Given this list of marker genes TMEM183A, PIGC, SMYD3, FBXW2, RCOR3, TMEM106B, TTC13, LPGAT1, YY1AP1, RAP2A, EFNA1, SUN1, WDR26, CHKA, NUAK1, HSPA14, GORASP2, PRCC, MFF, NCK2, SYNJ2, TOR3A, RPS6KC1, SLC29A1, CAMSAP2, AFP, ARF1, MYH4, TMEM260, MKKS, H1-0, RBM34, TUG1, ATRN, CEBPA, CREB3L2, FGFR4, UXS1, SCAMP3, ZNF281, here is a description of the gene set: from publication Boyault S, Rickman DS, de Reyniès A, Balabaud C, Rebouissou S, Jeannot E, Hérault A, Saric J, Belghiti J, Franco D, Bioulac-Sage P, Laurent-Puig P, Zucman-Rossi J (PMID 17187432) Up-regulated genes in hepatocellular carcinoma (HCC) subclass G12, defined by unsupervised clustering Hepatocellular carcinomas (HCCs) are a heterogeneous group of tumors that differ in risk factors and genetic alterations. We further investigated transcriptome-genotype-phenotype correlations in HCC. Global transcriptome analyses were performed on 57 HCCs and 3 hepatocellular adenomas and validated by quantitative RT-PCR using 63 additional HCCs. We determined loss of heterozygosity, gene mutations, promoter methylation of CDH1 and CDKN2A, and HBV DNA copy number for each tumor. Unsupervised transcriptome analysis identified 6 robust subgroups of HCC (G1-G6) associated with clinical and genetic characteristics. G1 tumors were associated with low copy number of HBV and overexpression of genes expressed in fetal liver and controlled by parental imprinting. G2 included HCCs infected with a high copy number of HBV and mutations in PIK3CA and TP53. In these first groups, we detected specific activation of the AKT pathway. G3 tumors were typified by mutation of TP53 and overexpression of genes controlling the cell cycle. G4 was a heterogeneous subgroup of tumors including TCF1-mutated hepatocellular adenomas and carcinomas. G5 and G6 were strongly related to beta-catenin mutations that lead to Wnt pathway activation; in particular, G6 tumors were characterized by satellite nodules, higher activation of the Wnt pathway, and E-cadherin underexpression. CONCLUSION: These results have furthered our understanding of the genetic diversity of human HCC and have provided specific identifiers for classifying tumors. In addition, our classification has potential therapeutic implications because 50% of the tumors were related to WNT or AKT pathway activation, which potentially could be targeted by specific inhibiting therapies. species: Homo sapiens Human Gene Set: BOYAULT_LIVER_CANCER_SUBCLASS_G12_UP